Given this list of marker genes APOC3, APOA1, APOC2, APOE, APOA4, APOB, APOA2, MTTP, SAR1B, P4HB, here is a description of the gene set: Human Gene Set: REACTOME_CHYLOMICRON_ASSEMBLY Chylomicron assembly studied in species Homo sapiens